The following is a description of a gene set: Reactome Pathway: SHC1 events in EGFR signaling This event has been computationally inferred from an event that has been demonstrated in another species.<p>The inference is based on the homology mapping from PANTHER. Briefly, reactions for which all involved PhysicalEntities (in input, output and catalyst) have a mapped orthologue/paralogue (for complexes at least 75% of components must have a mapping) are inferred to the other species. electronically inferred by orthology from the curated human pathway part of: Signaling by EGFR species: Mus musculus, and this is the list of marker genes: Hras, Tgfa, Egfr, Areg, Epgn, Btc, Grb2, Shc1 (NCBI Gene Id 20416)